The following is a description of a gene set: The process in which the anatomical structures of the outflow tract are generated and organized. The outflow tract is the portion of the heart through which blood flows into the arteries. studied in species Mus musculus Mouse Gene Set: GOBP_OUTFLOW_TRACT_MORPHOGENESIS, and this is the list of marker genes: Thbs1, Tbx2, Lrp6, Jag1, Sox17, Sema3c, Tgfb2 (transforming growth factor, beta 2), Folr1, Dvl1, Ctnnb1, Nrp1, Sec24b, Ednra, Dvl3, Six1, Fgfr2, Foxc2, Fgf8, Greb1l, Bmpr2, Acvr1, Vangl2, Atf2, Bmp7, Ilk, Ryr1, Rbpj, Notch1, Lrp2, Twist1, Vegfa, Jun, Tbx20, Tgfbr2, Zfpm1, Smarca4, Nedd4, Npy1r, Crkl, Dvl2, Wnt11, Eng, Nrp2, Gata4, Hand2, Foxh1, Hey2, Ext1, Tbx3, Robo1, Nkx2-5, Tbx1, Mir452, Dicer1, Foxc1, Tgfbr3, Tfap2a, Isl1, Eln (elastin), Pitx2, Zfpm2, Mef2c, Eya1, Nipbl, Robo2, Fzd2, Gja5, Hey1, Cited2, Npy2r, Fzd1, Sox11, Nog, Bmp4, Parva, Hif1a (NCBI Gene Id 15251), Prickle1, Dhrs3, Sfrp2, Plxnd1, Smad4, Smad6, Gata6, Heyl, Msx2, Cdc42, Npy5r (neuropeptide Y receptor Y5), Edn1, Bmpr1a, Hes1, Ankrd11